Given this list of marker genes PB1, TGFB1, SLC25A6, NA, here is a description of the gene set: species: Homo sapiens Reactome Pathway: Influenza Virus Induced Apoptosis Influenza A virus induces apoptosis in a variety of ways including activation of host TGF-beta by expression of viral NA, M1 and M2 proteins, and by the binding of viral PB1-F2 to host mitochondrial adenine nucleotide translocator 3 (ANT3). part of: Influenza Infection